The following is a description of a gene set: Human Gene Set: GOMF_HISTONE_ACETYLTRANSFERASE_BINDING Binding to an histone acetyltransferase. species: Homo sapiens, and this is the list of marker genes: EGR1, PAX6, CEBPB, EID1, STAT1, MYOCD, FOXP3, MTF1, BCAS3, SIRT2, TAF7, KAT2B, MED1, CITED2, GLI3, KANSL1L, MEF2A, PCNA, TRIP4 (thyroid hormone receptor interactor 4), NR4A3, CREB1, KANSL1, ECD, SP1, ZBTB7A, TRIM68